Given this list of marker genes Ptgs2, Mef2c, Ass1 (NCBI Gene Id 11898), Hdac3, Mtss1, Spp1, Mmp2, Mapk7, Klf4, Hdac5, Socs5, Src (Rous sarcoma oncogene), Plec, Nfe2l2, Tfpi2, Klf2, Ptk2b, Pkd2, Has2, Xbp1, here is a description of the gene set: Any process that results in a change in state or activity of a cell (in terms of movement, secretion, enzyme production, gene expression, etc.) as a result of a fluid shear stress stimulus. Fluid shear stress is the force acting on an object in a system where the fluid is moving across a solid surface. Mouse Gene Set: GOBP_CELLULAR_RESPONSE_TO_FLUID_SHEAR_STRESS studied in species Mus musculus